Given this list of marker genes PHACTR4, NODAL, DLC1, IRX2, BCL10, SFRP2, IFT172, SCRIB, GRHL2, ZEB2, TSC2, NOG, NCKAP1, SLC39A12, PTK7, SIX1, WDR83, IRX3, SEMA4C, FZD6, CDK20, PTCH1, MED12, STK3, HIF1A, CFL1, WNT6, TGFB2, BRD2, HES5, OPA1, ST14, MTHFR, VANGL2, GDF7, BBS4, SPINT1, RARG, IFT57, NUP50, RPS7, CLUAP1, ALX1, IFT52, STIL, BMP5, CTHRC1, BMP7, TGFB1, PRKACA, HAND1, SALL4, RGMA, CTNNB1, OVOL2, TULP3, CELSR1, WNT5A (Wnt family member 5A), TEAD2 (TEA domain transcription factor 2), WNT9B, MTHFD1L, ADM, MKS1, WNT4, PLXNB2, SOX9, IRX1, CC2D2A, RALA, SEC24B, SIX4, SPECC1L, SDC4, SUFU, TWIST1, DEAF1, ARHGAP35, FOLR1, MIB1, LUZP1, MTHFD1, HNF1B, TRIM71, GREM1, STK4, FUZ, GATA3, RET, GRHL3, OSR1, CITED2, IFT122, KAT2A, PAX2, SPINT2, LMO4, VASP, BMP4, PAX8, SOX8 (NCBI Gene Id 30812), SFRP1, KDM2B, TSC1, TGIF1, PRICKLE1, TMED2, LHX2, GLMN, LIAS, FZD3, APAF1, LRP2, DVL2, GDNF, CASP3, PFN1, TRAF6 (TNF receptor associated factor 6), PRKACB, ABL1, CECR2, RARA, TCTN1, HS2ST1, COBL, SKI, KIF20B, here is a description of the gene set: The morphogenesis of an embryonic epithelium into a tube-shaped structure. Human Gene Set: GOBP_EMBRYONIC_EPITHELIAL_TUBE_FORMATION studied in species Homo sapiens